The following is a description of a gene set: species: Homo sapiens The process whose specific outcome is the progression of the skeleton over time, from its formation to the mature structure. The skeleton is the bony framework of the body in vertebrates (endoskeleton) or the hard outer envelope of insects (exoskeleton or dermoskeleton). Human Gene Set: GOBP_SKELETAL_SYSTEM_DEVELOPMENT, and this is the list of marker genes: BBX, CSGALNACT1, SMAD5, PRELP, DLG1, EPHA2, IRX5, FBN1, HYAL1, MATN1, TBX3, SP3, HOXC8, ALPL, CACNA1S, HOXC5 (NCBI Gene Id 3222), LIPA (NCBI Gene Id 3988), FBXW7, ARSL, SMAD7, LRRC17, RASSF2, LNPK, OTOR, TNFRSF11B, HEXA, PTGER4, HOXA9, SULF2, IFT80, EFEMP1, IFT172, CCDC154, MCPH1, HOXC11, BMP5, TCOF1, BBS1, ANKH, HOXC9, LRP5, TP53, SNAI1, TGFBI, MYCN, ADAMTS4, DYNC2I1, ZNF219, BMP8A, RFLNB, AMELX, HOXA7, MMP16, SIX2, DLX5, ZIC3, NPR2, ATG9A, TYROBP, SLC2A10, SFRP4, HOXD1, MIR21, GPLD1, GJA5, SOX11, FGFR1, MYF5, RFLNA, SNORC, DHRS3, SLC38A10, TGFBR2, CDH11, ADAMTS7, SFRP2, HOXC4 (NCBI Gene Id 50712), HOXC6, SPEF2, LOX, SLC35D1 (solute carrier family 35 member D1), OSR1, GLI2, BNC2, HOXB7, BBLN, NPPC (natriuretic peptide C), PTH1R, IL17F, WNT7A, AHSG, KDR, INPPL1, SOX6, SERP1, CD44, RPL13, MBOAT2, DEAF1, MUSTN1, ITGB6, CDX1, SOX9, GATA3, HOXB3, PKDCC, RUNX3, LECT2, NAB1, CDK20, CHSY1, FGFR2, GH1, TRIM45, COL1A2, PCGF2, ATF2, CHADL, PBXIP1, MAPK3, MGP, MEGF8, EXT2, HES7, COL5A2, SLC39A14, COL18A1, NDST1, UCMA, GJA1, CHST11, EDN1, TFAP2A, MKKS, GNA11, LAMA5, DLX4 (distal-less homeobox 4), WNT2B, ATP6AP1, HAND1, TMEM119, CTC1, SHOX2, DLX6, FOXC1, VDR, ACP5, MIGA2, SNX19, HIF1A, FBN2, THBS3, WDR19, PRDX1, NOTCH2, MED12, DDRGK1, COL6A1, FUZ, NIPBL, WFIKKN1, FGR, INHA, SMPD3, HOXA10, NCAN, IHH, LEPR, HAPLN1, CITED2, GGCX, TSKU, BMP4 (bone morphogenetic protein 4), WNT5A, PCSK5, PITX2, P3H1, CYP26B1, PPIB, NOTUM, ACVR2A, FGF8, MYOC, CMKLR1, MMP14, FGFRL1, PDGFC, PKD1, TGFB1, COL3A1, NOG, GDF11, RPL38, TLL1, BBS2, PAFAH1B1, PRKRA, CREB3L2, PEX7, HHIP, COL9A2, COL13A1 (collagen type XIII alpha 1 chain), GALNT3, WNT10B, RARG (retinoic acid receptor gamma), MAPK11, WDR5, TGM2, DLL3, GNAS, HOXB1, HOXA4, ITGB8, HEXB, HOXD3, POR, HOXA1, SRD5A1, PLXNB1, MAF, DSCAML1, FGF9, ENSG00000274276, HOXD9, EXTL1, PDGFA, CHRDL2, DMRT2, MMP9, OGN, NSD2, RUNX2, FOXC2, HOXB4, DCHS1, MBTPS2, PRPSAP2, SPP2, TWSG1, GLI3, RBP4, COL11A1, ZBTB16, MATN3, GDF10, TTC9, HOXD8, HOXB8, FREM1, GPR68, EYA1, LRRK1, LTBP3, TWIST1, HOXD12, GRHL2, SRD5A2, TIPARP, CHAD, GHRL, TCF15, HOXD11, PLS3, SFRP1, TRAPPC2, EDNRA, SCX, HOXA13, HOXA5, EIF2AK3, CBS, HOXC10 (homeobox C10), ARID5A, HAPLN2, ETS2 (ETS proto-oncogene 2, transcription factor), HOXD4, HOXA11, SNX10, BGLAP, ZMPSTE24, CDKN1C, NFIA, ANXA2, ATP7A, FBLN5, INSIG2, GLG1, HMGA2, SIX1, NKX3-2, FOSL2, SLC9B2, IFT140, HOXB6, UFD1, RARA, STC1, EBP, HYAL2, SPNS2 (SPNS lysolipid transporter 2, sphingosine-1-phosphate), HYAL3, FGF18, LILRB1, BMPR1A, OSR2, LTF, PITX1, SEMA4D, TNN, RSPO2, THRA, BMP8B, BMP3 (bone morphogenetic protein 3), RAB33B, HOXD10, DLX2, RHOA, ACVR2B (NCBI Gene Id 93), AKAP13, MTHFD1, HSD17B1, HOXA3, SLC39A1, BMP7, SULF1, IGF1, BMP6, LUM, CTNNB1, CNMD, PTPRC (NCBI Gene Id 5788), HAND2, SCIN, VKORC1, PSEN1, MAPK14, TEAD4, PRRX1, PAX1, ANKRD11, SMAD2 (NCBI Gene Id 654050), RIPPLY2, MEPE, PRKG2, IFT25, ECM1, BMP1, CHRD, SATB2, CCN2, MYC, BCAN, IFITM5, MMP2, COL2A1, TRPV4, HOXB9, RYR1, HSD17B7, P2RX7, GSC, LOXL2, SIX4, SH3PXD2B, WDR48, COL11A2, TRPS1, SMAD1, ADAMTS12, SBDS, NR5A2, WNT5B, SLC26A2, TGFB2, COL19A1, SLC10A7, MTHFD1L, TBX1, EN1 (NCBI Gene Id 2019), USP1, PHOSPHO1, BMI1, MAP2K6, MSX2, ERRFI1, XYLT1, WNT7B, PTPN11, WNT1, JAG2, HOXD13, CER1, RARB, MEF2C, POC1A, FOXP1, PTHLH, NLE1, EVC, INSIG1, SLC39A3, TNFSF11, ZEB1, PBX1, TMEM107, RYK, CLDN18, EIF4A3 (NCBI Gene Id 9775), ACVRL1, TULP3, ACTN3, FST, HAPLN4, TP63, CCN1, OPA3, SP5, NFATC2, WWOX, RANBP3L, NAB2, MMP13, LHX1, EPYC, TIMP1 (NCBI Gene Id 7076), LEP, UNCX, FAM20C, COL27A1, ATG9B (NCBI Gene Id 442783), MDK, SHH, BMPR1B, HOXB2, ALX1, RAI1, CHD7, MDFI, AMER1, DLX1, ZFAND5, DYM, WFIKKN2, KAT2A, PTH, TBX4, FRZB (frizzled related protein), ASH1L, COMP (NCBI Gene Id 5659), PLEKHA1, B3GLCT, SRF, RPS6KA3, MBTD1, NPR3, TGFBR1 (NCBI Gene Id 7046), TRIP11, OPTC, NODAL, HAPLN3, GDF5, BGN, CCN3 (NCBI Gene Id 4856), CHI3L1, TIFAB, NFIB, HOXA2, HAS2, CYTL1, FGF4, GDF2, NEUROG1, SHOX, FLVCR1, DCANP1 (NCBI Gene Id 140947), GDF6, SNAI2, VCAN, CCN4, HOXA6, SIGLEC15, VEGFA, TBX15, CLEC3A, FGF6, BPNT2, ADGRG6, DDR2, WNT9A, SGPL1, WNT11, COL10A1, HOXB5, BMP10, GHR, ALX4, PDGFRA, DLX3, CSRNP1, ACAN, RB1, AXIN2, ACD (NCBI Gene Id 82538), BMP2, OSTN, RUNX1, CTSK (cathepsin K), MEX3C, SOX5, PAPSS1, MKS1, BMPR2, HES5, ALX3, SKI, GREM1, PHEX, TAPT1, EXT1, SERPINH1, P2RX5, FOXN3, SMAD3, WNT9B, MSX1, GDF3, ACP2, RAB23, LARGE1, ARID5B (AT-rich interaction domain 5B), MOSMO, KIAA1217, FGFR3, TLE5, PUM2, SRC (NCBI Gene Id 6714), PAPPA2, BARX2, PAX5, PAX7, TMEM38B, ASXL1 (NCBI Gene Id 23393), FGF2, RDH10, COL1A1